Given this list of marker genes SEMA3B, MCM5, ZNF462, LXN, BORA, E2F1, LAMB1, CENPA, here is a description of the gene set: studied in species Homo sapiens from publication Zhou T, Chou J, Mullen TE, Elkon R, Zhou Y, Simpson DA, Bushel PR, Paules RS, Lobenhofer EK, Hurban P, Kaufmann WK (PMID 17404513) Cell cycle genes significantly (p =< 0.05) changed in fibroblast cells at 2 h after exposure to ionizing radiation. The changes in global gene expression in response to DNA damage may derive from either direct induction or repression by transcriptional regulation or indirectly by synchronization of cells to specific cell cycle phases, such as G1 or G2. We developed a model that successfully estimated the expression levels of >400 cell cycle-regulated genes in normal human fibroblasts based on the proportions of cells in each phase of the cell cycle. By isolating effects on the gene expression associated with the cell cycle phase redistribution after genotoxin treatment, the direct transcriptional target genes were distinguished from genes for which expression changed secondary to cell synchronization. Application of this model to ionizing radiation (IR)-treated normal human fibroblasts identified 150 of 406 cycle-regulated genes as putative direct transcriptional targets of IR-induced DNA damage. Changes in expression of these genes after IR treatment derived from both direct transcriptional regulation and cell cycle synchronization. Human Gene Set: ZHOU_CELL_CYCLE_GENES_IN_IR_RESPONSE_2HR